Given this list of marker genes PRODH, BLOC1S6, GAD1, NR1H4, ADHFE1, HAL, ASL, MTHFS, GGT1, TAT, UROC1, PRODH2, GAD2 (NCBI Gene Id 2572), GLUD2, GCLC, FTCD, SLC7A11, ALDH18A1, GOT1, GLUD1, GLUL, OAT, AADAT, ALDH5A1 (NCBI Gene Id 7915), ATCAY, GCLM, AMDHD1, GLS2, NAGS, FPGS, GOT2, ALDH4A1, GLS, DGLUCY, here is a description of the gene set: The chemical reactions and pathways involving glutamate, the anion of 2-aminopentanedioic acid. species: Homo sapiens Human Gene Set: GOBP_GLUTAMATE_METABOLIC_PROCESS